The following is a description of a gene set: from publication Gao S, Yan L, Wang R, Li J, Yong J, Zhou X, Wei Y, Wu X, Wang X, Fan X, Yan J, Zhi X, Gao Y, Guo H, Jin X, Wang W, Mao Y, Wang F, Wen L, Fu W, Ge H, Qiao J, Tang F (PMID 29802404) Human Gene Set: GAO_LARGE_INTESTINE_ADULT_CF_GOBLET_CELL_SUBTYPE_1 species: Homo sapiens, and this is the list of marker genes: FAM174B, TRPA1, CAPN9 (calpain 9), FFAR4, LRRC26, FER1L6, CBFA2T3, TBX10, FAM177B, FAXDC2, PFKFB4, TPSG1, ARHGAP31, CEP192P1, B3GNT6, GALNT8, CCNJL, MB, RASD2, GPR153, SYTL5, FRMD3, MYRIP, KLK15